The following is a description of a gene set: studied in species Homo sapiens Impacted tooth Human Gene Set: HP_IMPACTED_TOOTH A tooth that has not erupted because of local impediments (overcrowding or fibrous gum overgrowth)., and this is the list of marker genes: SH3BP2 (NCBI Gene Id 91018), FLNA, CDH11, LMNA (NCBI Gene Id 7816), ZMPSTE24, HOXD13, PTH1R